Given this list of marker genes Mir6236 (microRNA 6236), n-R5s88, Ctnna3, Gata2, Ppp6r3, here is a description of the gene set: Genes containing one or more binding sites for (Mnx1) in their promoter regions (TSS -1000,+100 bp) as identified by GTRD version 20.06 ChIP-seq harmonization. Mouse Gene Set: MNX1_TARGET_GENES studied in species Mus musculus from publication Yevshin I, Sharipov R, Kolmykov S, Kondrakhin Y, Kolpakov F (PMID 30445619)